Given this list of marker genes TTC33, ZRANB1, PCDH15, PRRG1, DST, SLITRK2, FBXO30, DPH2 (NCBI Gene Id 1802), ZBTB20, ADAM12, RWDD4, TET1, ANKRD62, NPAT (NCBI Gene Id 8067), NALF1, SLC25A37, ZNF782, LHX1, ADD3 (adducin 3), TP53TG3B, KCND2, ZSWIM5, PRICKLE2, CLVS1, PDE7B, RAD54L2, SH3TC2, CBX5, SLC44A1, CNTNAP4, AEBP2, CADPS2, CNOT7, POU5F2, ANO3, SLC1A2, POU2F1, SLF2, PAX7, EBF3, PURB, ALX1, MMP8, XPR1, CHORDC1, PAK3, IDI2, CCDC141, SESN3 (NCBI Gene Id 143686), CHIC1 (cysteine rich hydrophobic domain 1), FAM135A, ALDH6A1, SLC5A7, SEC16B, TENT4B, TMEM33, CXCL14, BEND4 (BEN domain containing 4), LRATD1, VAMP1, DNAJC6, CD2AP, AADACL4, ZNF354A, SEC24A, PCBP2, CCDC91, TANC2, CHSY3, KAT7, PKHD1, NFIB, NEBL, GDAP2, PAPOLA, ZBTB41, CSRNP3, ZNF382, GPR155, TMX1, JTB, MFAP5, NEXMIF, C1orf141, ZNF367, HS2ST1, KLHL14, ZMAT4, ESRRG, PLCH1, HYCC2, IDE, POPDC3, MARK2, LILRA1, GABPB2, WDR44, BANK1, UBA5, ARPP19, BCL11A, KRTAP11-1, PRKAA1, ISM1, GALNT7 (NCBI Gene Id 51809), SNAP29, UPK1B, PDIA4, UBTF, EFEMP1, HOMER1, MEGF11 (NCBI Gene Id 84465, multiple EGF like domains 11), WAPL, ARK2C, PALM2AKAP2, RPGRIP1L, NAE1, OGFOD1, CCDC50, TRDN, BROX, MTHFS, LAMA4, CD93, B3GLCT, SHTN1, SCML2, ARID5B, SLC22A15, VWA2, KRTAP3-2, SLC5A12 (NCBI Gene Id 159963), TTC21B, FNIP1, LAMC2, SCMH1, PAN3, IKZF3, SSBP2, AZI2, RUNDC3B, HNRNPF, ATPSCKMT, FRS2, KCTD11, TOR1AIP1, PNMA1, DIXDC1, MOSPD2, CAAP1, KIF5B, RAB5A, PEX13, TP53TG3D, MEIOC, DNAL1, TNRC6B, AHRR, SYNPO2, WDR35, NPL, PIKFYVE, MYCL, BLZF1, GRK5, CFAP52, KCNB1, EYA4, STRBP, FAHD1, ARL5A, BLCAP, VAX1, GSPT2, HOOK3, KLF12, DENND1B, KIAA0232, TFAM, TBCEL, TRIP11, USP31, LECT2, SLC25A46, TRMT112, PABIR3, RSPO2, CCDC186, LIAT1, ASPH, CMAS, BACH2, S1PR3 (NCBI Gene Id 414320), NELL2, YTHDF1, ZNF146, CUL2, MBTD1, DNAH6, STRN, SLC41A2, KLRG1, DSCAML1, FZD3, EPHB1, ONECUT2, ITGB8, SMC5, DNAJC10, AGO3, RNF128, IPCEF1, ING3, ATP6V1A, NQO1, STEAP2, HSPB1, FGF13, FAM111A, DSG2, LNPK, SPATA31F1, ATF7IP, KIAA1191, TMEM200B, ZNF148, GLO1, CSE1L, HNRNPK, STMN1, TP53TG3, HDAC1, BTLA, CSTA, FMNL3, SPOCK1 (SPARC (osteonectin), cwcv and kazal like domains proteoglycan 1), TBRG1 (transforming growth factor beta regulator 1), ST8SIA1, LIFR, POGK, RARRES1, DDHD1, METTL15, ELAVL1, ITGAM, KDM6A, IP6K1, TAPT1, FMN1, GNG12, ZNF567, LPP, BASP1, KCNK1 (NCBI Gene Id 3775), ATOSA, GNAO1, C18orf54, TBC1D5, PTPN4, ZNF677, PLEKHJ1, ST20-MTHFS, RNMT, PHF3, RBM28, UBE2H, RRM2, CLASP2, NUDT21, TNFAIP8, RAPH1, TGFBRAP1, AAK1, RERE, ETV1, CRIPT, INO80D, CDK6 (cyclin dependent kinase 6), KCNG3, TBK1, MAPK8, ZSCAN12, NEUROD4, FBXW11, HCN1, PARP16 (NCBI Gene Id 54956), KCNMB2, NFKBIZ, COPA, RAD9A, NAV1, ATF6, XRN1, KCNK9, BSN, ITGB6, CAMSAP1, APOL4, RAB2A, JCAD, BTBD7, VSIG10, MTF1, ZKSCAN4, ELK1 (NCBI Gene Id 2002), ZFHX4, ADAM22, RALGPS2, TRHDE, KDSR, CEP97, APEX1, TNFSF4, MAEA, RANBP3L, SEC62, HSPE1, PRSS12, SEMA3A, TMEM168, PTK2, GABPA, PCNX1, F8 (coagulation factor VIII), NCOA2, ACKR3, SIK3, ARL8B, KBTBD6, STX12, CYP3A7-CYP3A51P, GABRA4, ZFX, TENM1, EPG5, PKD2, TP53INP1, PJA2, APH1A, SPRED1, MAGI2, CREBL2 (cAMP responsive element binding protein like 2), CD1E, DCX, RALA, PDE6H, GPRC5B, SLC2A14, GABPB1, SH3KBP1, DNAJC27, UBE2K, CILK1, ACSL6, PIAS2, RORA, KLF6, PABIR2, MAP2, ZFPM2, WBP4, VPS36, GAS2, CAMK1D (NCBI Gene Id 57118, calcium/calmodulin dependent protein kinase ID), BCL6B, RESF1, ENC1, ATP8A1, RAD50, HNRNPU, LATS1 (large tumor suppressor kinase 1), SP1, WNT3, ETAA1, ANO1, TNFRSF11B, TBC1D19, CDCA7L, OPRM1, PHAX, KDM7A, SRSF10, DLG4, CCNYL1, TRIM5, SIX4, COX19, DPY19L1, here is a description of the gene set: Genes predicted to be targets of miRBase v22 microRNA hsa-miR-539-5p in miRDB v6.0 with MirTarget v4 prediction scores > 80 (high confidence targets). Human Gene Set: MIR539_5P from publication Chen Y, Wang X (PMID 31504780) studied in species Homo sapiens